The following is a description of a gene set: Neighborhood of SERPINB5 serpin peptidase inhibitor, clade B (ovalbumin), member 5 in the GNF2 expression compendium Human Gene Set: GNF2_SERPINB5 Neighborhood of SERPINB5 species: Homo sapiens, and this is the list of marker genes: GJB3, AHNAK2, UPP1, ALDH1A3, LAMA3, GPR87, KRT17 (keratin 17), SERPINB5, KRT5, CDH3 (NCBI Gene Id 1001), PTHLH, TP63, LAMC2, SFN, ANXA3, AREG, F3, FERMT1, S100A14, S100A2, ANXA8, FGFBP1, CLCA2, GJB5, PERP, COL17A1, KRT19, LAMB3